The following is a description of a gene set: Mouse Gene Set: GOMF_ARACHIDONATE_14_15_EPOXYGENASE_ACTIVITY Catalysis of an NADPH- and oxygen-dependent reaction that converts arachidonic acid to cis-14,15-epoxyeicosatrienoic acid. species: Mus musculus, and this is the list of marker genes: Cyp2j11, Cyp2c39, Cyp2c40, Cyp2j13, Cyp2c23, Cyp2c29, Cyp2c38, Cyp2j5, Cyp2j6, Cyp2j8, Cyp2j7, Cyp2j9, Cyp2j12